The following is a description of a gene set: Enables the transfer of L-glutamate from one side of a membrane to the other. L-glutamate is the anion of 2-aminopentanedioic acid. studied in species Mus musculus Mouse Gene Set: GOMF_L_GLUTAMATE_TRANSMEMBRANE_TRANSPORTER_ACTIVITY, and this is the list of marker genes: Slc17a8, Slc1a2, Slc7a11, Slc25a13, Slc1a7, Slc25a18, Grik1, Slc1a1, Slc25a22, Slc17a6, Slc1a3, Slc38a6, Slc1a6, Slc17a7, Slc25a12